Given this list of marker genes SPRED2, ID3, TRIB1, SOWAHC, KLF6, KBTBD2, FOSB, ETS2, NR4A1, DUSP1, ZFP36, DNAJB1, ID1 (inhibitor of DNA binding 1), NAP1L1, CCN1, GEM, ATF3, DUSP5, MYC, AEN, SIK1, FOSL1, EDN1, MAFF, CCN2, NEDD9, EGR1, NR4A2, EPHA2, KDM6B, TNFRSF11B, KLF10, HBEGF, LIF (NCBI Gene Id 3976), BCL10, BHLHE40, JUNB, IER2, DUSP2, TIPARP, PLEKHO2, FOS, EGR3, RYBP, HES1, ARC, MIR22HG, NR4A3, DLX2, TNFRSF12A, IER3, AREG, NAB2, F2RL1, EGR4, MCL1, JUN, here is a description of the gene set: ErbB receptor ligands, epidermal growth factor (EGF) and heregulin (HRG), induce dose-dependent transient and sustained intracellular signaling, proliferation, and differentiation of MCF-7 breast cancer cells, respectively. In an effort to delineate the ligand-specific cell determination mechanism, we investigated time course gene expressions induced by EGF and HRG that induce distinct cellular phenotypes in MCF-7 cells. To analyze independently the effects of ligand dosage and time for gene expression, we developed a statistical method for estimating the two effects. Our results indicated that signal transduction pathways convey quantitative properties of the dose-dependent activation of ErbB receptor to early transcription. The results also implied that moderate changes in the expression levels of a number of genes, not the predominant regulation of a few specific genes, might cooperatively work at the early stage of the transcription for determining cell fate. However, the EGF- and HRG-induced distinct signal durations resulted in the ligand-oriented biphasic induction of proteins after 20 min. The selected gene list and HRG-induced prolonged signaling suggested that transcriptional feedback to the intracellular signaling results in a graded to biphasic response in the cell determination process and that each ErbB receptor is inextricably responsible for the control of amplitude and duration of cellular biochemical reactions. Genes up-regulated in MCF7 cells (breast cancer) after stimulation with EGF. from publication Nagashima T, Shimodaira H, Ide K, Nakakuki T, Tani Y, Takahashi K, Yumoto N, Hatakeyama M (PMID 17142811) Human Gene Set: NAGASHIMA_EGF_SIGNALING_UP studied in species Homo sapiens